Given this list of marker genes CPTP, ESYT2, ESYT1, ARF1 (NCBI Gene Id 375), ESYT3, CLN3, PLEKHA8, GLTP, here is a description of the gene set: Glycosphingolipid transport species: Homo sapiens Human Gene Set: REACTOME_GLYCOSPHINGOLIPID_TRANSPORT